The following is a description of a gene set: Human Gene Set: HP_ATELECTASIS studied in species Homo sapiens Atelectasis Collapse of part of a lung associated with absence of inflation (air) of that part., and this is the list of marker genes: DNAAF2, ODAD3 (outer dynein arm docking complex subunit 3), HYDIN, CFAP74, GP1BB, PAX3 (NCBI Gene Id 5077), SEC24C, DNAL1, AGR2, RREB1, RSPH1, STK36, DRC1, STAT3, PLEC, SFTPC, B3GALT6, ASAH1, ARVCF, UFD1, DNAAF4, LTBP4, JMJD1C, NHLRC2, DNAH9, TTC12 (NCBI Gene Id 54970), DNAI2, OFD1, DNAAF11, LRRC56, DNAI1, RSPH4A, ZMYND10, DNAAF1, SFTPB, MCIDAS, DNAAF5, DNAH5, CCDC39, HIRA, TP73, SPAG1 (NCBI Gene Id 6674), ESAM, DNAH1, NME8, CYBB, RPGR, TBX1, ODAD1, C1QB, NME5, DNAAF6 (NCBI Gene Id 139212), OCRL, TSC2, CCNO, CFAP221, NEK10, GAS2L2, CXCR4, TSC1, RSPH3, CFAP298, ABCA3, RSPH9, DNAJB13, CFAP300, COMT, LAMA2 (NCBI Gene Id 3908), GAS8, RIPK4, ODAD4, DNAAF3, FOXJ1, NKX2-1, ODAD2, SPEF2, CCDC40, DNAH11